The following is a description of a gene set: Catalysis of the hydrolysis of terminal non-reducing N-acetyl-D-hexosamine residues in N-acetyl-beta-D-hexosaminides. studied in species Mus musculus Mouse Gene Set: GOMF_BETA_N_ACETYLHEXOSAMINIDASE_ACTIVITY, and this is the list of marker genes: Hexa, Chil3, Hexb, Oga (O-GlcNAcase), Gm2a, Hexd